Given this list of marker genes PCDH10, SFRP1, WIF1, DKK1, SFRP5, CDX2, IHH, HHIP, MGMT, SFRP2, here is a description of the gene set: from publication Schlesinger Y, Straussman R, Keshet I, Farkash S, Hecht M, Zimmerman J, Eden E, Yakhini Z, Ben-Shushan E, Reubinoff BE, Bergman Y, Simon I, Cedar H (PMID 17200670) Many genes associated with CpG islands undergo de novo methylation in cancer. Studies have suggested that the pattern of this modification may be partially determined by an instructive mechanism that recognizes specifically marked regions of the genome. Using chromatin immunoprecipitation analysis, here we show that genes methylated in cancer cells are specifically packaged with nucleosomes containing histone H3 trimethylated on Lys27. This chromatin mark is established on these unmethylated CpG island genes early in development and then maintained in differentiated cell types by the presence of an EZH2-containing Polycomb complex. In cancer cells, as opposed to normal cells, the presence of this complex brings about the recruitment of DNA methyl transferases, leading to de novo methylation. These results suggest that tumor-specific targeting of de novo methylation is pre-programmed by an established epigenetic system that normally has a role in marking embryonic genes for repression. Genes expressed in normal colon; they undergo down-regulation in tumors through DNA methylation. studied in species Homo sapiens Human Gene Set: SCHLESINGER_METHYLATED_IN_COLON_CANCER